Given this list of marker genes Ptpn1, Fbxo32, Mapk8, E2f3, Lypd3, Ptk2b, Gapdh, Dicer1, Il12b, Trip10, Edn1, Mir124a-1hg, Eif5a, Hsp90aa1, Adcyap1, Mfn2, Apoh, Ifng, Col6a1, Agtr1a, Dnmt1, Zc3h12a, Erbb4, Stk4, Hey2, Gch1, Map2k5, Gngt1, Eng, Gria4, Pcmt1, Sirt1, Hsf1, Pdpk1, Igf1, Dynlt1f, Bag3, Acot1, Nol3, Hspb6, Nrg1, Npm1, Capn2, Mff, Gnb1 (guanine nucleotide binding protein (G protein), beta 1), Atp2a2, Cxcr2, Sod2, Gapdhrt2, Notch1, Myocd, Mapk7, Cdkn2a, Trp53 (transformation related protein 53), Ilk, Slc25a4 (NCBI Gene Id 11739), Cflar, Grk2, Bcl2, Dynlt1c, Ambra1, Casp12, Cftr, Sirt4, Gsk3b, Apaf1, Foxo1, Gata4, Trem1, Sfrp2, Esr1, Zfas1, Sirt5, Lifr, Stub1, Tbx1, Igfbp3, Dipk2a, Map2k4, Jak2, Mdk, Hand2, Dynlt1a, Dynlt1b, Gapdhrt, Rbm10, Ghrh, Arrb1 (arrestin, beta 1), Atg7, Hmox1, Nupr1, Grp, Ltk, Lrp6 (low density lipoprotein receptor-related protein 6), Slc7a5, Gata6, Pten, Atg5, Pparg, Camk2d, Nfe2l2, Camk2a, Pdcd4, Bmpr1a, Agt, Alox12, Capn1, Pik3r1, Adcy10, Bag1, Fndc1, Bnip3, Rps6ka2, Pax8, Pde1a, Tigar, Hmgcr (NCBI Gene Id 218474), Map3k5, Arrb2, Qki (NCBI Gene Id 66145), Pou4f2, Ppp1r10, Nkx2-5, Rapgef3 (NCBI Gene Id 70104), Smad4, Igf1r, Hspa8, Rgl2, Atf4, Nr4a3, Dmpk, Il12a, Kifap3, Cav1, here is a description of the gene set: Mouse Gene Set: GOBP_MUSCLE_CELL_APOPTOTIC_PROCESS A form of programmed cell death induced by external or internal signals that trigger the activity of proteolytic caspases, whose actions dismantle a muscle cell and result in its death. A muscle cell is a mature contractile cell, commonly known as a myocyte, that forms one of three kinds of muscle. species: Mus musculus